The following is a description of a gene set: studied in species Homo sapiens Any process that stops, prevents or reduces the frequency, rate or extent of vascular smooth muscle cell proliferation. Human Gene Set: GOBP_NEGATIVE_REGULATION_OF_VASCULAR_ASSOCIATED_SMOOTH_MUSCLE_CELL_PROLIFERATION, and this is the list of marker genes: MIR503, MIR638, MIR362, MIR140, CDKN1B, TAFA5, MEF2C, MIR185, MIR133A1, GSTP1, NDRG2, SOD2, MIR665, ADIPOQ, MIR96, MIR34A, BMP4, MIR339, MIR424, MYOCD (myocardin), GPER1, CDKN1A, PPARG, RBM10, PTEN, PRKG1, GNA12, MIR182, MIR15A, MIR223, APLN, TPM1, TGFB3, MIR4632, CNN1, MIR214, RGS5, EFEMP2, PDCD4, MIR137, MIR1298, MIR1-1, IL10